The following is a description of a gene set: Human Gene Set: GSE4748_CTRL_VS_CYANOBACTERIUM_LPSLIKE_STIM_DC_3H_DN from publication Macagno A, Molteni M, Rinaldi A, Bertoni F, Lanzavecchia A, Rossetti C, Sallusto F (PMID 16717116) Genes down-regulated in monocyte-derived dendritic cells: untreated versus LPS like antigen from O. planktothrix (3h). species: Homo sapiens A cyanobacterial LPS antagonist prevents endotoxin shock and blocks sustained TLR4 stimulation required for cytokine expression. We report the identification and biologic characterization of an LPS-like molecule extracted from the cyanobacterium Oscillatoria Planktothrix FP1 (CyP)., and this is the list of marker genes: TIMM23, MYOF (myoferlin), NUCB2, STAB1 (stabilin 1), TMEM126A (transmembrane protein 126A), CFB, RCN1, BASP1, TMEM106A, CHCHD3, TPI1, CD3D, TSPAN31, ACAT1, DNAJC19, MSR1, FAM162A, G6PC3, RPS27L, NAMPT, ADSL, GBP4, NUDT9, PFDN1, RCAN3, GIPC1, METTL1 (methyltransferase 1, tRNA methylguanosine), PON3, GLA, RNH1, NAB2, IKBKE, SNX5, SCPEP1, FCGR2B, CD69, PRDX2, MRPL11, CXCL9, TUBG1, SHMT2 (NCBI Gene Id 6472), GNL3, CISD3, CCDC86, RNF121, CXCL3, SLC25A4, C4B, ASL, EMC7, PLK3, GOT1, PSMC5, ECE2, PAQR4, BAX, CD151, TIMM22, GAS2L3, SLC39A14, TNFRSF9, GCSH, TRMT1, RETSAT, NDUFV3, GZMB, TOP1MT, SERPINB9, ERP44 (NCBI Gene Id 23071), MIF (NCBI Gene Id 4282), TNFSF10 (NCBI Gene Id 8743), IDH3A, PSMB6, MAD2L2, IER3, RENBP, TUBB6, WASHC5, NRP1, FBXO6, AURKB, PDZD11, EIF1AY, ETF1, DUSP10, RBMS2, PSAT1, NIBAN2, TPCN2, GBP2, NAA50, PSMD1, NDFIP2, HAUS7, AOPEP, PWWP2B, RPN2, MED9, METAP2, SLC27A1, TGIF1 (NCBI Gene Id 91941), ORC2, SPCS1, PRELID1, CCL4, EID1, SKA3, CMTM3, COPS5, BRIP1, PSMD12, H1-0, BCL2L1, ARMCX3, PDCD5, TMEM237, COQ7, SORBS1 (sorbin and SH3 domain containing 1), LGALS1, GRHPR, CD8B, DNAJC2, NDUFAB1, ANXA5, ROPN1L, BOLA3, TCEAL8, YIF1B, CCL2, PRDX4, ACOD1 (aconitate decarboxylase 1), BTG3, SHTN1, IPO4, RBMS1, NIT2, PFKM, NUDT2, GTF3A, NOP2, CNIH1, IMMT, GFUS, SLC15A3, SH3PXD2B, DRG2, COA7, KGD4, GALK1, CXCL1, WDR18, FASTKD3, NDUFS6, UNG, THYN1, MRPS14, ANAPC11, TMEM256, CD200R1L, TBCB, ATF3, DOCK7, THY1, CA13, ADAM9, UQCR11, IQGAP3, NDUFB6, CUL9, C3AR1, BLTP3A, TTLL12 (tubulin tyrosine ligase like 12), ZFAND2A, CFAP410, FBXW9 (NCBI Gene Id 84261), BSG, CHST14, EIF2S2, RHOV, GTF2F2, ADAM17, CCL13, C1QB, IFNG, MPHOSPH6, GNB1, NDUFC1, MRPL45, C15orf48, POLK, DDX1, MYDGF, NAA20, MMP14, TRAPPC3, MRPS18A, CXCL16, SRSF2, RSPH3, AIG1